The following is a description of a gene set: Any process that activates, maintains or increases the rate of the cascade of processes induced by the cell cycle regulator phosphoprotein p53, or an equivalent protein, in response to the detection of DNA damage. studied in species Mus musculus Mouse Gene Set: GOBP_POSITIVE_REGULATION_OF_DNA_DAMAGE_RESPONSE_SIGNAL_TRANSDUCTION_BY_P53_CLASS_MEDIATOR, and this is the list of marker genes: Ifi211, Ddx5, Zfp385a, Ankrd1, Spred2, Ifi204, Pmaip1, Pla2r1, Ing4, Atm, Eef1e1, Atr, Ifi205, Cdkn2a, Spred1, Rpl26, Znhit1, Hic1